The following is a description of a gene set: Human Gene Set: HP_TYPICAL_ABSENCE_SEIZURE Typical absence seizure studied in species Homo sapiens A typical absence seizure is a type of generalized non-motor (absence) seizure characterized by its sudden onset, interruption of ongoing activities, a blank stare, possibly a brief upward deviation of the eyes. Usually the patient will be unresponsive when spoken to. Duration is a few seconds to half a minute with very rapid recovery. Although not always available, an EEG would usually show 3 Hz generalized epileptiform discharges during the event., and this is the list of marker genes: EEF1A2, HNRNPK, PTEN, JRK, DPM1, BCKDK, PLPBP, SLC2A1, WAC, PRMT7, HNRNPC, NHLRC1, CACNA1H, DYRK1A, GRIN1, ALDH7A1, FBXO28, COL3A1, GABRG2, FRRS1L, SATB2, ADNP, PUM1, ASAH1, GABRB3, ADGRG1, GRIN2A, GABRA1, ALMS1, FZR1, CACNB4, ALDH4A1